The following is a description of a gene set: Mouse Gene Set: MORI_MATURE_B_LYMPHOCYTE_UP studied in species Mus musculus from publication Mori S, Rempel RE, Chang JT, Yao G, Lagoo AS, Potti A, Bild A, Nevins JR (PMID 18922927) The Emu-myc transgenic mouse has provided a valuable model for the study of B-cell lymphoma. Making use of gene expression analysis and, in particular, expression signatures of cell signaling pathway activation, we now show that several forms of B lymphoma can be identified in the Emu-myc mice associated with time of tumor onset. Furthermore, one form of Emu-myc tumor with pre-B character is shown to resemble human Burkitt lymphoma, whereas others exhibit more differentiated B-cell characteristics and show similarity with human diffuse large B-cell lymphoma in the pattern of gene expression, as well as oncogenic pathway activation. Importantly, we show that signatures of oncogenic pathway activity provide further dissection of the spectrum of diffuse large B-cell lymphoma, identifying a subset of patients who have very poor prognosis and could benefit from more aggressive or novel therapeutic strategies. Taken together, these studies provide insight into the complexity of the oncogenic process and a novel strategy for dissecting the heterogeneity of B lymphoma. Up-regulated genes in the B lymphocyte developmental signature, based on expression profiling of lymphomas from the Emu-myc transgenic mice: the mature B, and this is the list of marker genes: Gga2, Ctsh, Scd1, H2-M3, Sgpp1, Adrb2, Irf8, Cd83, Lpp, Ppm1m, Rab8a, Pxk, Fam76b, Sdf2, Vps28, Cnot6l, 2410002F23Rik, Ms4a1, H2-Oa, Ncf4, Adcy7, Cmtm6 (CKLF-like MARVEL transmembrane domain containing 6), Ptpn6, Phtf2, Fcer2a, Cd74, Zfp36l1, Ighd, Tmod3, Morf4l1 (NCBI Gene Id 627352), Foxd4, Add1, Smap2, Crybg1, Osbpl5 (oxysterol binding protein-like 5), Samhd1, Ptprc, Igkv17-127, Bglap3, H2-DMa, Rmi1, Ets1, Wdr43, Pip4k2a, Sell, Cxcr5, Arhgef3, Abca1, Map2k1, Gnpnat1, Pea15a, Ifngr1, Sh3bp2, Rasa3, Mycbp2, Pou6f1, Ythdc1, Apoe, Man1a, H2-Eb1, H2-Ob, Ctss, Dgcr6, Cer1, Neat1, Mfsd14b, Eeig1, Lat2, Rap1gds1, Map3k8, Tbc1d14, H2-DMb1 (NCBI Gene Id 14999), Il10rb, Pisd, Rgs14, H2-Aa, Slc4a7, Ripor2, Il2rg (interleukin 2 receptor, gamma chain), Macf1, Sorl1, Barx1, Cr2, Grcc10, Cers2, Ebi3, Gpr65, Igkv14-111, Lcp1, Jak2, Mcl1, Id3, Il10ra, Mef2c, B4galnt1